The following is a description of a gene set: Genes up-regulated in B lymphocytes: naïve versus memory. studied in species Homo sapiens from publication Covens K, Verbinnen B, Geukens N, Meyts I, Schuit F, Van Lommel L, Jacquemin M, Bossuyt X (PMID 23613519) The recent discovery of the human B1 cells, identified by the expression of CD20, CD27 and CD43 in absence of expression of CD70 and CD69 has been subject of debate. Some studies have raised the possibility that these cells are B cells differentiating towards the plasmablast and plasma cell stage rather than being the human counterpart of murine B1 cells. No further in depth studies have been performed. Therefore, a functional comparison was made between, the proposed B1 cells and plasmablasts. We observed that for several functional characteristics (distribution of isotypes of spontaneously producted antibodies, production of antigen-specific antibodies after vaccination with both T-cell dependent as well as T-cell independent antigen, the proposed B1 cells behaved similar to plasmablasts. In addition, we were able to differentiate the proposed B1 cells in vitro, indicating that they are not from a distinct lineage as the murine B1 cells. Gene expression analysis revealed that these cells cluster between memory B cells and plasmablasts, contradicting them being the genuine human counterpart of murine B1 cells, rather revealing a preplasmablast phenotype. Human Gene Set: GSE42724_NAIVE_VS_MEMORY_BCELL_UP, and this is the list of marker genes: TNFSF10, CCNYL1, NINJ2, POU1F1 (POU class 1 homeobox 1), SLC35G6, C9orf72, C11orf71, SYS1, PAFAH1B1, IL1B, PRSS23 (serine protease 23), LOXL4, KCNIP4, SLC30A6, KLRG1, CHRNB1, LSAMP, BAZ1A, SH2B2, HIRA, GCH1, TXN, SUCO, GBP7, MKKS (MKKS centrosomal shuttling protein), ACP5, DCBLD2, SAXO1, CELA3B, UNC5A, HLA-DMB, TMEM183A, SAMHD1, NFKBIE, CD38, SLC8B1, PGAM2, IDNK, FBLN7, MTF2, GSR, COA5, GNAS-AS1, METTL6, RGL1, AGAP2, SERPINA11, NLRP3, AIF1, CLDN5, SPOPL, CCN3, CDC73, NCK1, INTS12, KIF9, COPZ1, ANKRD7, RAB11FIP1, CAMLG, CYB561A3, FAM20B, GET4, MFSD8, LALBA, HP, MRGBP, GSS, ACVR1B, TLR9, SGPP2, BMP7, HRCT1, RALGDS, GLRX, C1QTNF9, ADORA2B, ASB6, PSMF1 (NCBI Gene Id 9491), FLAD1, ATG16L1, MON1A, SENP6, FYB1, PRPF40A, FICD, IL4I1, ETFRF1, IRAK2, COG1, MRPL10, STAT1, TYW5, CILP2, POLR3D, DUSP14, GBP2, SLC6A4, NMT1, MX2, PPFIBP2, SRA1, HCAR2, KLHL15, PLIN4, TMOD4, UNC13D, NPLOC4, MAP3K21, DGKH, PAPPA2, MOAP1, CPLX3, SCNM1, CFL2, MX1, WNT9B, RASGRP1, ALDH1A3, TMEM40, TCF25, FAXC, SMG8, ERBB2, FGFBP3, ALOX12, DNAJA1, MAP6D1, IFNAR1, CFLAR, GTF2A1, EHD1, ITGB7, MEIKIN, MSR1, FCGR1A, SETDB2 (SET domain bifurcated histone lysine methyltransferase 2), CXCL16, TRMT9B, NPPA, GPM6A, NRBP1, INHBB, AXDND1, FBP1 (NCBI Gene Id 2203), GUCA1B, DPM2, TMEFF2, MIR22HG, EXO5, PPP1R15A, PTGS2, NSUN5 (NCBI Gene Id 92116), UBC, DPF2, AFP, BIRC3, ACBD3, COQ8A, MARCO, GOT1L1 (NCBI Gene Id 137362), SPHK2, PHOSPHO2, BEND6, SCAND1 (NCBI Gene Id 92786), NCSTN, ATP6V0A2 (NCBI Gene Id 7854), HSPH1, PSMB10, HMGA1, APOOL, GOSR1, CYSLTR2 (cysteinyl leukotriene receptor 2), RTL6, PCDHB15 (protocadherin beta 15), RUNX3, ABCC10, GPD2, ANGPTL3, CA2, RABL3, PRSS45P, SCYL3, GABPB1 (GA binding protein transcription factor subunit beta 1), STIM2, TRPM5, GYPC, CHAT, PLP1, CMKLR1, LRRN2, STAM2, HRH3, PDZD11, LMO4, FLT3LG, CHIC1, TNIP1, APBB1, MYH11